The following is a description of a gene set: Reactome Pathway: Mitochondrial RNA degradation The human mitochondrial genome encodes two rRNAs, 22 tRNAs, and 13 proteins. The mitochondrial genome is transcribed from two divergent promoters into two large precursor RNAs, one from each strand, that are endonucleolytically processed into individual mRNAs, tRNAs, and rRNAs. Heavy strand (H-strand) DNA is significantly more G-rich than light strand (L-strand) DNA. Transcripts from the H-strand encode eight monocistronic mRNAs, two bicistronic mRNAs (MT-ATP8/6 and MT-ND4L/4), 14 tRNAs, and two rRNAs. Transcripts from the L‑strand encode only one mRNA (MT‑ND6), one long non-coding RNA (lncRNA), lncND6, which is antisense to MT-ND6, and eight tRNAs, and two long non-coding RNAs designated as lncND5, and lncCyt b RNA that are antisense to the coding mRNAs MT-ND5 and MT-CYB (CYTB, MT-Cytb). The L-strand and H-strand transcripts are complementary and, therefore, have the potential to form large double-stranded RNAs (dsRNAs), yet very little dsRNA is observed in wild-type mitochondria.<br>Both dsRNAs and normal mRNAs, tRNAs, and rRNAs are hydrolyzed by the SUPV3L1:PNPT1 complex, called the degradosome, which is located mostly in mitochondrial RNA granules (MRGs) adjacent to the DNA-containing nucleoid. Degradation appears to occur in subregions of MRGs called D-foci. SUPV3L1 is a helicase that unwinds double-stranded RNA to provide single-stranded substrate to the PNPT1 exonuclease. Additionally, G quadruplex structures in a subset of RNAs are unwound by GRSF1 to provide substrates to the SUPV3L1:PNPT1 complex. However, other RNAs are stabilized by GRSF1. The PNPT1 3'-5' exonuclease hydrolyzes RNAs to yield 4-5 nucleotide "nanoRNAs" which are further hydrolyzed to mononucleotides by the REXO2 dimer.<br>Degradation of mitochondrial RNAs is regulated by RNA-binding proteins: FASTK, FASTKD1-5, and the SLIRP:LRPPRC complex. SLIRP:LRPPRC binds throughout the mitochondrial transcriptome, including 12S rRNA, 16S rRNA, and 13 mRNAs, and acts to stabilize RNA structures, inhibit hybridization of complementary RNAs, and extend the half-lives of RNAs. Fas-activated serine/threonine kinase (FASTK) and its homologs FASTKD1-5 bind particular mitochondrial RNAs and affect their stability and processing. species: Homo sapiens part of: Metabolism of RNA, and this is the list of marker genes: MT-ND4L, TBRG4, MT-ND6, MT-RNR1, MT-CO2, MT-CYB, FASTK, MT-RNR2, FASTKD5, MT-ND3, MT-ATP8, FASTKD2, MT-CO1, MT-ND1, REXO2, MT-CO3, GRSF1, MT-ND2, LRPPRC (leucine rich pentatricopeptide repeat containing), MT-ATP6, MT-ND5, MT-ND4, SLIRP, SUPV3L1, PNPT1